The following is a description of a gene set: Mouse Gene Set: GOBP_CONVERGENT_EXTENSION species: Mus musculus The morphogenetic process in which an epithelium narrows along one axis and lengthens in a perpendicular axis., and this is the list of marker genes: Nkd1, Ptk7, Zfp568, Wnt5a, Lrp6, Trim28, Dvl2, Lbx2 (NCBI Gene Id 16815), Wnt11, Sfrp5, Sfrp1, Sfrp2, Nphp3, Dvl1, Mesp1, Vangl2, Frzb, Wnt5b